The following is a description of a gene set: from publication Chen Y, Wang X (PMID 31504780) Genes predicted to be targets of miRBase v22 microRNA mmu_miR_6918_5p in miRDB v6.0 with MirTarget v4 prediction scores > 80 (high confidence targets). Mouse Gene Set: MIR_6918_5P studied in species Mus musculus, and this is the list of marker genes: Rbm14, Hic2, Trim33, Glis2, Gbp6, Mtcl2, Htra3, Kdm5b, Guca2a, Drg1, Vash2, Frs2, Nova2, Utp11, Asb12, Snai3, Tmem106a, Adamts14 (ADAM metallopeptidase with thrombospondin type 1 motif 14), Gstm6, Peak1, Ap2s1, Pde7a, Pcgf3, Cdc34, Stat3, Pom121, Igf2bp2, Anapc7, Pmepa1, Tspan14, Alx4, Amz2, Tmem154, Naa60, Pak3, Piezo2 (piezo-type mechanosensitive ion channel component 2), Stom, Gbp10, Rab6b, Nf2, Syn3, Acsm5, Cnot9, Zcchc14, Lhfpl4, Adat1, B3gnt7, Ms4a19 (membrane-spanning 4-domains, subfamily A, member 19), Marchf9 (NCBI Gene Id 216438), Cyp21a1, Arhgef10, Tbx5, Phyhip, Lax1, Snx27, Adrb3, Atg13, Gja5, Cenpq, Chst4, Rab11fip5, Chd9, Clic5, Abl2, Ppp1r15b, Nectin2, Ark2c, Cebpzos, Arid3b, Pxk, Ezh1, Zfp691, Sumo1, Gnaq, Dhh, Ap3b2, Maco1, Fbxw8, Chrm1, Macrod2, Dtx4, Zfp882, Fgf14, Panx2, Lpcat4, Igf2, Zfp867, Usp3, Epha6, Map3k3, Desi1, Csdc2, Galnt1, Cab39, Rnf157, Arhgap25, N4bp1 (NEDD4 binding protein 1), Dsg1c, Irs1, Zxdc, Sfxn5, Sprn, Mrps2, Stam, Mideas, Dagla, Irx4, Tbc1d24, Aff3, Mllt6, Apol8, Septin12, Angptl2, Glyctk, Marchf6, Pou2f1, Zfp398, Igdcc3, Zscan4d, Rhoq, Cadm3, Rps6ka1, Fem1a, Igf2bp1 (NCBI Gene Id 98709), Trim71 (tripartite motif-containing 71), Ddi2, Rnf145, Anxa5, Gnptab, Lztfl1, Mindy2 (NCBI Gene Id 235461), Vta1, Pip5k1c, Celsr2, Dlx2, Zscan4c, Rap2c, Rnf150, Aadacl3, Dcaf11, Lrig1, Cyp26b1 (cytochrome P450, family 26, subfamily b, polypeptide 1), Ttc28, Xpo7, Lrrc59, Usp37, Abhd17a, B230219D22Rik, Pdss2, Prmt1, Cep164, Zdhhc1, Ntrk1, Rnf225, Zscan4f, Ildr1, Ifit1, Gja1, Eif3j2, Abr, Aqp8, Tnfrsf1b, Hmga2, Fzd1, Mier2, Rnf185, Pde7b (phosphodiesterase 7B), Il20, Rbfox2, Dstn, Hnrnpu, Rad9b, Tspan33, Fdft1